Given this list of marker genes Sorbs1, Chd4, Jag1, Scd2, Slc25a10, Akt1, Tpsb2, Clca3a2, Tns1, Pik3r1, Csnk2a1, Car8, Runx1, Kcnb1, Gpam, Lratd1, Adissp, Taok1, Ogt, Lrp5, Ppp2r5b, Stom, Stat5b, Jchain, Prrx1, Pank3, Wasl, Zbtb7b, Qki, Slc38a10, Scd1, Cpd, Gys2, Brd8, Ehd3, Lipg, Prkacb, Atp6v0a1, Rbbp4, Smarca4, Prpf19, Pi16, Smc6, Ptk2b, Clec3b, Zbtb20, Mef2c, Malat1, Cavin1, Ank, Igfbp5, Ecm1, Sod3, Prelp, Timp2, Dhx36, Fgg (NCBI Gene Id 99571), Kif1c, Hipk2, Cp, Hsd17b11, Cnot3, Ubtf, Igfals, Nfib, Hdlbp, Pdap1, Resf1, Il6ra, Lpgat1, Sppl2a, Wnk1 (WNK lysine deficient protein kinase 1), Ccnd2, Ehd1, Scd3, H3c15, Epas1, Trac, Akap9, Map4k2, Lalba, Nfic, Tmem143, Kcnk3, Gbp7, Nfil3, Nfix, Mapk8, Secisbp2l, Cyth1, Acly, Steap3, Ndst1, Rassf3, Csn1s2a, Ip6k1, Igha, Pcyt1a, Dnm2, Myo1c, Dpysl3, Btn1a1, Gm2a, Sntb2, Pten, Galnt2, Csn2, Eif4ebp2, Tbl1x, Rab5c, Sod2, Sox9 (NCBI Gene Id 70015), Bltp2, Keap1, Ykt6, Extl3, Eif3c, Ets1, Ebf3, Atp1a3, Itsn2, Cux1, Rad23a (NCBI Gene Id 93802), Sirpa, Ywhag, Ube4a, Sncg, Nrip1, Ehd2, Cygb, Lck, Arhgef2, Ighm, Slc2a5, Pdcd6ip, Vapb, Acaca, Trbc2, Sec61a1, Ppp6r3, Crim1, Syncrip, Nr2c2, Egln1, Ogfr, Chi3l1, Gusb, Rab5b, Tmem45b, Tcf7, Fads2, Gys1, Qpctl, Tpr, Cant1, Slc2a4, Atp8a1, Norad, Tgfbr1, Sfpq, Fscn1, Brd4, Aplp2, Mapk8ip1, Dapk1, Lama4, Igfbp4, Mbtps1, Epb41l2, Mapk14, Kdm5a, Lasp1, Bpnt1, Igkc, Akt2, Zeb2, Lipa, Zfp91, Fzd4, Grb10, Coro1a, Il6st, Phgdh, Ms4a1, Sftpd, Tyr, Gpd1, Mlxipl, Nfatc3, Tmem79 (transmembrane protein 79), Gid4, Fto, Comt (catechol-O-methyltransferase), Ddx6, Pcmtd1, Abcc3, Eif4g1, Sh2b3, Kdm5c, Xist, here is a description of the gene set: studied in species Mus musculus Genes up-regulated during pubertal mammary gland development between week 6 and 7. Expression microarray analysis identified over genes regulated during puberty in the mouse mammary gland. Most prominent were genes whose expression increased in parallel with pubertal development and remained high thereafter. Members of the Wnt, transforming growth factor-beta and oestrogen-signalling pathways were significantly overrepresented. Comparison to expression data from CITED1 knockout mice identified a subset of oestrogen-responsive genes displaying altered expression in the absence of CITED1. Included in this subset are stanniocalcin2 (Stc2) and amphiregulin (Areg). Chromatin immunoprecipitation revealed that ERalpha binds to oestrogen response elements in both the Stc2 and Areg genes in the mammary gland during puberty. Additionally, CITED1 and ERalpha localize to the same epithelial cells of the pubertal mammary gland, supporting a role for interaction of these two proteins during normal development. In a human breast cancer data set, expression of Stc2, Areg and CITED1 parallel that of ERalpha. Similar to ERalpha, CITED1 expression correlates with good outcome in breast cancer, implying that potential maintenance of the ERalpha-CITED1 co-regulated signalling pathway in breast tumours can indicate good prognosis. Mouse Gene Set: MCBRYAN_PUBERTAL_BREAST_6_7WK_UP from publication McBryan J, Howlin J, Kenny PA, Shioda T, Martin F (PMID 17486082)